The following is a description of a gene set: species: Homo sapiens Genes up-regulated in comparison of stimulated CD4 Th1 cells at 48 h versus stimulated CD4 Th2 cells at 48 h. Immune cell-specific expression is one indication of the importance of a gene's role in the immune response. In order to identify such patterns, we set out to broadly profile gene expression in a variety of immune cells. Human Gene Set: GSE22886_TH1_VS_TH2_48H_ACT_UP from publication Abbas AR, Baldwin D, Ma Y, Ouyang W, Gurney A, Martin F, Fong S, van Lookeren Campagne M, Godowski P, Williams PM, Chan AC, Clark HF (PMID 15789058), and this is the list of marker genes: TLL2, UCP1, CDR2L, FLRT3, SORBS1, COX6A2, MAP3K14, PELI1, ATP6V1B1, HOXA6, FJX1, FBXO40, CEND1, ADH7, TBX21, MOBP, CHRNB2, UQCRFS1, CD83, BARX2, DHX34, SCGB1A1, BFSP1, DLX5, RTN1, RAP1GAP, PPP4R1, ADAMTS12, VARS1, CDC42BPB, PNLIPRP1, CFP, CRISPLD2, GLS2, KCNA10, FHL3, CTSH, PREX2, CDH19, CFHR5, GPR6, CRNN, FADS3, AOPEP, SMYD5, COLEC12, TMEM53, CLDN7, ST14, PLXNB2, STXBP1, FGF21 (NCBI Gene Id 26291), RASL10A, SSBP3, SPACA9, THY1, TMEM11, CKB, CDC42EP1, IL1RAPL1, NRCAM, GNL3LP1, HDLBP, DDAH1, CT55, BACH2, SARS2, DECR2, CHRNA4, MAOA (NCBI Gene Id 441491), POM121L2, CLIC2, PEG3, ABCA4, PTPRO, PLA2G7, LILRA2, LGALS3, TNFRSF12A, JUN, POU2AF1, COX10, POU1F1, SLC35F2, KRT15, EN1, DEPP1, PLCG2, ITGA10, CDHR2, TBXA2R, S100A7, SPRY1, EREG, MYO19, OLIG2, ATF5, SLC15A2, CD226, PEX7, KRT20, ACRV1, GNG7, LTBP2, VENTX, FAH, IER3, CDK20, PPP1R15A, GCNT2, ENPEP, CCDC57, NCALD, HROB, TRIM49, GOLM1, TFR2, NR2E1, ANXA2P2, FZD7, PMEPA1, HSPB1, ECE1, EDA2R, RFPL3, HCRTR1, CPN2, FGF7, KIF21B, RIPK2, VWF (von Willebrand factor), TNP2, LPAL2, SYT17, KRT84, CXCL11 (NCBI Gene Id 6373), XCR1, TRPS1, OLFML2A, ZNF205, INKA2, PROX1, ZNF408, CUX1, BRS3, EEF2, RCAN1, C10orf95-AS1, ITPK1 (inositol-tetrakisphosphate 1-kinase), ZC3H7B, HOXC8, SOCS6, KCNN4, B3GALNT1, SLC11A1, ANKRD28, AOC1, LDLRAD4, DLG2, BACE1, CTNND2 (catenin delta 2), DNAJB5, NDOR1, PLCE1, DPM2, ERCC1, CAVIN3, CD320, NPY, PKD2L1, MYOG, TCP11L1, AGT, TAPT1, DGKI, LAMB3 (laminin subunit beta 3), DDIT3, DTNB, LSAMP, MTX1, PAX5, FN3K, ZNF197, APOBEC1, EPHB3, TUBB2B, SPA17, IFNG, SGK1, EMP1, PRKCZ, MRAS, SIPA1L1, ERG, TTLL4, BARX1, ADRA2C, GABRG2